Given this list of marker genes ARID1B, EBP, ANK1, LIMK1, ROR2, SRD5A3, TMCO1, FZD2, HNRNPK, KMT2D, RPL10, STX1A, MAN2C1, SUGCT, TBX4, ENPP1, DVL3, DICER1, GREB1L, TBX6, EIF4H, DHCR7, PAFAH1B1, SMC5, GFRA1, LETM1, KIF15, DVL1, KCNK9, DMP1, CLIP2 (CAP-Gly domain containing linker protein 2), RMRP, MASP1, NADSYN1, FGFR3, ITGA8, LBR, DCHS1, FGFR2, PRR12, FLNB, TBX5, NDUFB11 (NCBI Gene Id 54539), METTL27, NODAL, H4C5, GTF2I, GTF2IRD2, PRMT7, ELN, BMPER, KANSL1, FGFRL1, PAM16, ZFX, GDF3, NCF1, WNT7A, PIGG, SCARF2, ODC1, NSUN2, PHEX, SETBP1, CAPRIN1, CTBP1, SMAD4, SETD5 (SET domain containing 5), YWHAE, RUNX2, SMOC1, TNFRSF1A, GNB2, TBX1 (T-box transcription factor 1), FUCA1, POLA1, CPLX1, RFC2, CTCF, SPOP, NXN, ASXL1, FAT4, TCF4, TAF1, PTH1R, RTTN, PDGFRB (NCBI Gene Id 5159), BAP1, HAAO, COX7B, FUZ, TP63, TRIP11, KDM6A, RPS19, RET, PSMD12, LIFR, SLC26A2, CDK10, KMT2A, HIC1, FKBP6, WNT5A, NSD1, MEOX1, SHANK3, HCCS (holocytochrome c synthase), CAMK2G, ERF, HLA-B, USP9X, B3GLCT (beta 3-glucosyltransferase), BICD2, TMEM270, HOXD13, LIG4, NELFA, ERI1, ZNF699, CCL2, OTUD6B, TWIST2, FANCF, EXTL3, WLS, FANCL, COLEC10, VANGL2, GDF6, DYRK1A (dual specificity tyrosine phosphorylation regulated kinase 1A), HOXA13, DHPS, FGF20, MNX1, APC2, RAB23, SMG9, BAZ1B, POC1A, NOTCH3, WNT9B, GNS, DNAJC30, MED12, TBXT, FANCB, BUD23, B9D2, NSD2, NCAPG2, VPS37D, VANGL1, COL2A1, CAPN15, GTF2IRD1, CD96, ZIC3, AFF3, TBL2, AEBP1, DEAF1, here is a description of the gene set: An abnormality of the sacral bone. Human Gene Set: HP_ABNORMAL_SACRUM_MORPHOLOGY studied in species Homo sapiens Abnormal sacrum morphology